Given this list of marker genes GSR, MRPL34, DUSP6 (dual specificity phosphatase 6), ATP11A, HMGA1, DMP1, CP, TYK2 (NCBI Gene Id 7297), TNFRSF12A, PRSS8, DUSP1, CHKA, LIPE, SAT1, PLEKHB1, TNFRSF11B, HOXD12, INMT, CRABP2, EVX2, NID1, CEBPB, NUPR1, CCN2, BLNK, RARB, TM4SF1, TGFB3, TCIRG1, MLLT6, JUNB, MMP2, CA12, ZBP1, RESF1, AOX1, PRSS22, DHRS3, STK11, CAPN5, BHLHE40, MAST2, ESD, MSLN, FGF18, SKIL, PGPEP1, here is a description of the gene set: from publication Delacroix L, Moutier E, Altobelli G, Legras S, Poch O, Choukrallah MA, Bertin I, Jost B, Davidson I (PMID 19884340) Human Gene Set: DELACROIX_RAR_TARGETS_UP All-trans retinoic acid (RA) induces transforming growth factor beta (TGF-beta)-dependent autocrine growth of mouse embryonic fibroblasts (MEFs). We have used chromatin immunoprecipitation to map 354 RA receptor (RAR) binding loci in MEFs, most of which were similarly occupied by the RAR alpha and RAR gamma receptors. Only a subset of the genes associated with these loci are regulated by RA, among which are several critical components of the TGF-beta pathway. We also show RAR binding to a novel series of target genes involved in cell cycle regulation, transformation, and metastasis, suggesting new pathways by which RA may regulate proliferation and cancer. Few of the RAR binding loci contained consensus direct-repeat (DR)-type elements. The majority comprised either degenerate DRs or no identifiable DRs but anomalously spaced half sites. Furthermore, we identify 462 RAR target loci in embryonic stem (ES) cells and show that their occupancy is cell type specific. Our results also show that differences in the chromatin landscape regulate the accessibility of a subset of more than 700 identified loci to RARs, thus modulating the repertoire of target genes that can be regulated and the biological effects of RA. species: Mus musculus Genes bound by RARG and up-regulated by tretinoin (all-trans retinoic acid, ATRA) in MEF cells (embryonic fibroblast).